The following is a description of a gene set: studied in species Homo sapiens Human Gene Set: GOMF_LIPID_TRANSMEMBRANE_TRANSPORTER_ACTIVITY Enables the transfer of a lipid from one side of a membrane to the other., and this is the list of marker genes: SLC22A11, SLC22A2, ABCD1, SLC27A2, SLC27A6, SLC43A3, SLC10A2, SLCO2A1, ABCG4, SLC2A1, AKR1C4, SLC22A7, ABCA4, ABCC11, SLC10A1, SLC27A5, CD36, ABCC1, ABCC4, ABCD4, SLCO1C1, SLC27A1, SLC22A9, SLC22A8, CEACAM1, SLC22A6 (solute carrier family 22 member 6), SLC22A1, RBP4, FABP5, SLC51B, MFSD2A, ABCD2, SLCO1A2, FABP3 (fatty acid binding protein 3), SLC5A8, ABCG1, SLCO3A1, ABCA12, SLC10A6, SLCO2B1, SLC27A4, SLCO1B7, SLCO1B1, SLC10A5, FABP4, SLCO1B3, SLC10A3, ABCB11, ABCD3, SLCO1B3-SLCO1B7, ABCC3, STRA6, SLCO4A1, SLC10A4, SLC51A, FABP2 (fatty acid binding protein 2)